Given this list of marker genes ACKR2, SRRM4, EDNRA, TRAPPC14, GLP1R, TMEM120B, PARP11, MORC4, C9orf78, KCNIP1, ENTPD2, BAZ2A, PITPNM2, RHOC, POLH, PRG4, NPTXR, IGSF8, NOS1, AIF1L, RPL15, RELT (RELT TNF receptor), CCDC43, MNT, THTPA, RRP15, PACSIN1, VSIR, KRTAP4-11, VPS37C, HIPK2, BAZ2B, PNPLA2, PDE7A, AGPAT1, FGFR1OP2, AGAP2, STK35, TMEM276, DUSP8, CSF1R, DESI1, CAMK1, SOX13, FOXK1, VSIG10L, SLC12A4, MTF1, SLC25A23, KCND3, HOXB8, PCBD1, KCNQ2, ERF, COL6A1, SUFU, TAP1, G6PC3, IQSEC3, MRPL43, CALN1, KIF18B, NDST1, STX1A, ORAI2, KLC2, OAF, ARHGAP23, TMTC1, KCTD10, PSMB2, KCNQ4, CYP1A2, HOXA10, ARPC4-TTLL3, CIC, MVB12B, HK1, TOMM40, ATP8A2, DTX4, MPDU1-AS1, PNMA2, TNS1, SLC4A8, ALX4, LRRC4B, ELFN2, CHST3, MPP2, AHDC1, GRSF1, MYO1C, KCNK15, CAPZB, ADAM21 (NCBI Gene Id 8747), TMEM104, PRICKLE1, ALPG, PLEKHA5, C1RL, MYRF, INKA2, SLC7A1, NECTIN1, SHISA6, DLGAP4, PAPOLG, YPEL4, RPH3AL, DNAJB2, CASKIN1, NOX1 (NADPH oxidase 1), ABO, MECP2, RIMS3, NGFR, BICDL1, RNF44, ARHGDIA, SPRY4, SH3GL1, NLGN3, RAD51B, ABCB5, KSR2, EIF4EBP2, RAB3IL1, NOVA2, GLDN, RPRD2, CLIP2, NUP98, APCDD1 (APC down-regulated 1), CERCAM, ELAVL3, ANKRD45, UNC5B, RBMS2, PLAGL2, SV2C, CDR2L, COPS7B, AVPR2, DACT1, PACS1, SCN4B, STX2, MAFF, AR, VWA5B2, IQSEC1, RAB5B, PRR32, ELK1, PLCXD1, ANKRD52, SHISA7, SYNJ1, CPQ, SEC22B, PKNOX2 (NCBI Gene Id 63876), HYI, LZTS3, TIMP3, ZNF667, PTPRA, AGAP1, CNGA2, RTN3, LYN, CORO2B, ACP3, UTP11, FAIM2, PBX2, ATXN2L, APLNR, RNMT, CCDC180, PITPNM3, GFOD2, PLA2G4E, ABCG4, TFAP2B, MS4A4A, F11R, STIM1, CDKN1A, NHERF2, SYT7, SORCS1, GALNT2, HMGXB3, TTYH3, GNAT1, YWHAQ, SLC35F6, IKZF3, ARHGEF11, TMEM63C (NCBI Gene Id 57156), DUSP4, CYP26B1, RBM24, POLR1G, LENG8, ZFAND5, PXDC1, MAP3K9, SSBP3, ZNF544, SV2A, PRR12, TMEM252, CBX6, BSN, SERPINA1, ATP2A3, PTK2, MGAT5B, SCAMP4, NFIC, RFT1, ATXN1, PPM1F, MIEF2, CNNM1, SDK1, CARM1, CSNK2A1 (casein kinase 2 alpha 1), MYO10, PPM1J, POU2F2, LRP1, SBF1, CCDC69, PLXNA4, FNIP1, PLA2G2A, SDC3, PTPRJ, CSF2RB, RASSF5, TUBB4A, MDC1 (mediator of DNA damage checkpoint 1), PPP5D1P (NCBI Gene Id 100506012), CDC23, DDX18 (NCBI Gene Id 8886), NCOR2, CSDC2, PPP1R9B, FSCN1 (NCBI Gene Id 6624), NFIX, PHYHIP, GANAB, CDC42BPA, SARM1, SMG6, RAB11B, FURIN, ZBTB4, SREBF2, PIGR, ERI3, TSPAN18, NTSR1, RUSC1, ZSCAN30, ZNF385A, POU2AF1, CREB3L2, B9D1, USP37, SLC8A2, PURA, MEX3A, DPF3, ZNF518B, XKR6, SLITRK5, C2CD2L, GRK2, IL2RG, RNF38, RHO (rhodopsin), PNPO, RNF24, ARPC2, YBX2, MYH14, MEF2D (myocyte enhancer factor 2D), AP1S1, COL11A2, RAVER1, TPCN1, SLC6A11 (NCBI Gene Id 6538), FAT2, SLC2A4, MAPT, RPL32, TSKU, FAM131C, SYN2 (NCBI Gene Id 6854), NIBAN2, XYLT1, SYT15, SPRYD4, RAP1GAP2, FIBCD1, ALPL, POMT2, HOXC4, KRT75, DAB2IP, GGCX, MINK1, MLLT6, COL5A3 (collagen type V alpha 3 chain), EYA3, CTSD, GSK3A, DES, CASTOR2, MTA2, SH3BP2, MTCL2, TMEM184B, SLC22A23, BCL9, MXD3, KIF21B (kinesin family member 21B), ASIC1, ARFRP1, TAF4, FAM131B, VAMP2, AP2A1, MAVS, RBFOX2, POLR2E, SENP5, S100A5, ZNF710, ADAM12, GNAO1 (NCBI Gene Id 2775), TRIM67, SOX12, PIK3C2B, SYNGR1, PRR30, ZNF333, C1orf210 (chromosome 1 open reading frame 210), GPM6B, SUPT5H, CASP10, FOXP4, BET1L, IRGQ, PLEKHG2, NAV2, HCFC1, APOA5, SMARCD1, RNF222, NYNRIN, DAGLA, KIAA1549, MGRN1, WNT9B, RSPO4, WDTC1, SYNGAP1, ABCB8, DDAH1, TET3, RALB, RAB35, PIK3R2 (phosphoinositide-3-kinase regulatory subunit 2), NFASC, CSDE1, PPARD, ATF7, FANCF, ELAVL1, STARD9, THY1, BCL2L1, SAV1, PARVG, CSF1, MMP19, DEPDC5, FBXO10, NACC1, MKNK2, RALGDS, APRG1, DLK1, IFFO2, C20orf96, PA2G4, KHSRP, PAIP2B, N4BP1, RPS6KA2, ARNT2, KIF5A, here is a description of the gene set: species: Homo sapiens Human Gene Set: MIR6883_5P from publication Chen Y, Wang X (PMID 31504780) Genes predicted to be targets of miRBase v22 microRNA hsa-miR-6883-5p in miRDB v6.0 with MirTarget v4 prediction scores > 80 (high confidence targets).